The following is a description of a gene set: species: Mus musculus Mouse Gene Set: GOMF_STRUCTURAL_CONSTITUENT_OF_NUCLEAR_PORE The action of a molecule that contributes to the structural integrity of the nuclear pore complex, a protein-lined channel in the nuclear envelope that allows the transfer of macromolecules., and this is the list of marker genes: Nup155, Nup35, Nup62, Nup54, Tpr, Nup107, Nup133, Pom121, Pom121l2, Nup160, Nup214, Nup98, Ndc1, Nup62cl, Nup188, Nup58, Nup153, Nup93, Nup88, Nup85, Nup205